Given this list of marker genes ATF3, GSN, DUSP5 (NCBI Gene Id 1847), DDR2, GPNMB, PROS1, NID2, TRAPPC6A, GOLGA8A, ASNS (asparagine synthetase (glutamine-hydrolyzing)), FOS, VLDLR, PCK2, NNT, CFD, SEPTIN6, GADD45A, MYH10, SRGN, IL18, TGFBI, S100P, UGCG, TXNIP, OASL, OLFML2A, CSRP2, CLIC4, CPE, ANXA4, CD44, GARS1, CYP19A1, FGG, TUBA1A, CXCR4, HLA-C, C1R, TLE5, GSTA4, ISG15, IGFBP7, CBS, TM4SF1, FOLR1 (NCBI Gene Id 2348), CRIP1, TAF15, TNFAIP3, NUPR1, PHYH, NUCB2, ARL6IP1, CARS1, EML2, S100A4, CLDN7, CCNG2, CDKN1A, IL6, RGS2, CLU, CASP9, CASP4, ANXA1, C4BPA, KLRC3, here is a description of the gene set: Human Gene Set: GAJATE_RESPONSE_TO_TRABECTEDIN_UP from publication Gajate C, An F, Mollinedo F (PMID 12198119) species: Homo sapiens Genes up-regulated in HeLa cells (cervical carcinoma) by trabectedin. We have found that ecteinascidin-743 (ET-743) inhibited cell proliferation at 1-10 ng/ml, leading to S and G(2)/M arrest and subsequent apoptosis, and induced early apoptosis without previous cell cycle arrest at 10-100 ng/ml in cancer cells. ET-743-mediated apoptosis, did not involve Fas/CD95. ET-743 induced c-Jun NH(2)-terminal kinase (JNK) and caspase-3 activation, and JNK and caspase inhibition prevented ET-743-induced apoptosis. ET-743 failed to promote apoptosis in caspase-3-deficient MCF-7 cells, further implicating caspase-3 in its proapoptotic action. Overexpression of bcl-2 by gene transfer abrogated ET-743-induced apoptosis, but cells underwent cell cycle arrest. ET-743 triggered cytochrome c release from mitochondria that was inhibited by Bcl-2 overexpression. Inhibition of transcription or protein synthesis did not prevent ET-743-induced apoptosis, but abrogated ET-743-induced cell cycle arrest. Microarray analyses revealed changes in the expression of a small number of cell cycle-related genes (p21, GADD45A, cyclin G2, MCM5, and histones) that suggested their putative involvement in ET-743-induced cell cycle arrest. These data indicate that ET-743 is a very potent anticancer drug showing dose-dependent cytostatic and proapoptotic effects through activation of two different signaling pathways, namely a transcription-dependent pathway leading to cell cycle arrest and a transcription-independent route leading to rapid apoptosis that involves mitochondria, JNK, and caspase-3.